The following is a description of a gene set: Mouse Gene Set: REACTOME_POLB_DEPENDENT_LONG_PATCH_BASE_EXCISION_REPAIR POLB-Dependent Long Patch Base Excision Repair studied in species Mus musculus, and this is the list of marker genes: Adprs, Parp2, Lig1, Parp1, Parg, Apex1, Polb (polymerase (DNA directed), beta), Fen1